The following is a description of a gene set: studied in species Homo sapiens Human Gene Set: REACTOME_DNA_DAMAGE_BYPASS DNA Damage Bypass, and this is the list of marker genes: CUL4B, TRIM25, SPRTN, PCNA, UBA52, POLE2, RFC3, RFC2, POLD4, RFC1, MAD2L2, PCLAF, POLE4, POLD1, POLE, RAD18, POLD3, UBC, POLI, ISG15, RPS27A, USP10, RBX1 (ring-box 1), DTL, UFD1, POLH, NPLOC4, WDR48, UBA7, POLD2, UBE2L6, RCHY1, POLE3, RFC4 (NCBI Gene Id 5984), USP43, UBB, VCP, CUL4A, POLK, RPA2, RFC5, RPA3, REV1, UBE2B, DDB1 (NCBI Gene Id 1642), RPA1, REV3L, USP1